The following is a description of a gene set: This event has been computationally inferred from an event that has been demonstrated in another species.<p>The inference is based on the homology mapping from PANTHER. Briefly, reactions for which all involved PhysicalEntities (in input, output and catalyst) have a mapped orthologue/paralogue (for complexes at least 75% of components must have a mapping) are inferred to the other species. electronically inferred by orthology from the curated human pathway part of: Platelet homeostasis species: Mus musculus Reactome Pathway: Prostacyclin signalling through prostacyclin receptor, and this is the list of marker genes: Gng4, Ptgir, Gngt1, Gng3, Gng10, Gng5, Gnb2, Gng7, Gnb3, Gng8, Gng11, Gngt2, Gnb5 (guanine nucleotide binding protein (G protein), beta 5)